The following is a description of a gene set: This event has been computationally inferred from an event that has been demonstrated in another species.<p>The inference is based on the homology mapping from PANTHER. Briefly, reactions for which all involved PhysicalEntities (in input, output and catalyst) have a mapped orthologue/paralogue (for complexes at least 75% of components must have a mapping) are inferred to the other species. Reactome Pathway: Phospholipase C-mediated cascade: FGFR1 part of: Downstream signaling of activated FGFR1 electronically inferred by orthology from the curated human pathway studied in species Mus musculus, and this is the list of marker genes: Fgf6, Fgf17, Fgfr1, Fgf5, Fgf4, Kl (NCBI Gene Id 16591), Fgf1, Fgf10, Fgf22, Fgf23, Fgf8, Fgf20, Fgf2